The following is a description of a gene set: species: Mus musculus Mouse Gene Set: TUOMISTO_TUMOR_SUPPRESSION_BY_COL13A1_DN from publication Tuomisto A, Sund M, Tahkola J, Latvanlehto A, Savolainen ER, Autio-Harmainen H, Liakka A, Sormunen R, Vuoristo J, West A, Lahesmaa R, Morse HC 3rd, Pihlajaniemi T (PMID 19074901) Epithelial cells of mucosal surfaces are critical for maintaining immune homeostasis by aiding in the discrimination of pathogenic and commensal microorganisms and modulating the activities of antigen-presenting cells and lymphocytes. Functional breakdowns resulting in chronic infection and inflammation are associated with the development of hematologic and solid neoplasms for which detailed pathogenetic mechanisms are poorly understood. Mice heterozygous for a transgene Col13a1(del) expressing a mutant collagen XIII developed clonal mature B-cell lineage lymphomas originating in mesenteric lymph nodes (MLN). The tumors were associated with T cells and macrophages. The incidence of disease was reduced 2-fold in transgenic mice raised under specific pathogen-free conditions, suggesting a role for infectious agents. The lymphomas did not express the mutant collagen XIII, indicating that its influence on tumorigenesis was B-cell extrinsic and likely to be associated with collagen XIII-positive tissues drained by the MLN. Studies of the small intestines of transgenic mice showed that the subepithelial basement membranes (BM) were highly abnormal and that they exhibited heightened expression of genes involved in immune responses. These results define collagen XIII-dependent maintenance of the intestinal BM as a previously unappreciated component of immune responses and a critical determinant of cancer susceptibility. Genes down-regulated in small intestine tissue from transgenic mice expressing a mutant form of COL13A1, compared to normal controls., and this is the list of marker genes: Crp, Plscr2, Otop3, Afp, Gpr151, Ppm1j, Cyp2e1, Dbp, Ttr (NCBI Gene Id 98126), Bbox1, Foxq1, Mpp4, Cyp2c29, Apoa2, Gsta2, Mcam, Slc13a1, Cyp1a1, Bco2